The following is a description of a gene set: from publication Sawant DV, Sehra S, Nguyen ET, Jadhav R, Englert K, Shinnakasu R, Hangoc G, Broxmeyer HE, Nakayama T, Perumal NB, Kaplan MH, Dent AL (PMID 23053511) Genes down-regulated in T reg: BCL6 knockout versus wildtype. studied in species Homo sapiens gene expression data from wild-type and Bcl6-/- regulatory T cells in order to find genes regulated by Bcl6 in Treg cells Human Gene Set: GSE40493_BCL6_KO_VS_WT_TREG_DN, and this is the list of marker genes: GRK3, BDKRB1, ITGB4, ICOSLG, CD96, WNT1, TNP2 (transition protein 2), ACHE, SYT8, IZUMO1R, PAK5, PCSK9, NCCRP1, GRIK1, AKNAD1, C11orf87, C2CD4B, KRTAP3-1, CXCL13, SCN2B, ANO4, LRATD1, LHX2, RFX4, GPR151, GPR37L1, MIR365B, PREX2, GDPD4, SHBG, CBLC, PLB1, OSR2, KCNH2, SPACA3, HKDC1, GDPD2, CYP27B1, NPPA, USP18 (ubiquitin specific peptidase 18), MOXD2P, DGKK, SPRR2B, LELP1 (late cornified envelope like proline rich 1), GABRQ (gamma-aminobutyric acid type A receptor subunit theta), SYT13, FMO4, SLC45A2, MIR188, SFXN2, NT5C1A, CDHR4, MIR708, GPR27, DSG2, LPAR2, MIR185, CREB3L3, PNPLA3 (patatin like phospholipase domain containing 3), MYLK3, ACER2, TUBB4A, FOXA1, SAMD5, XIRP1, SIGLEC15, CCDC184 (coiled-coil domain containing 184), DYNLT2B, HDHD5, NEK11, MSMB, TSHB, ALG8, TTC16, ATP13A5, DSCAML1 (DS cell adhesion molecule like 1), ADARB2, VWA3B (von Willebrand factor A domain containing 3B), CTSLP3, RSPH6A, SEZ6L, PRSS36, OR1D2, COX4I1, ZP3, TEKT3, MIR210, GALNT14, SELP, KPNA7, IGFL3 (NCBI Gene Id 388555), NOG, CES5A, MYH8, MIR328, XCL1, CALHM3, TNFRSF19, CHRNE, CLDND2, SMIM31, ABCG8, MIR485, PCDH12, ATP4A, LYPD5, ZIC4, CAND2, SLC29A2, ITGB6, COL6A6, SNTG1, ARC, ACSS3, WFDC9, FMN2, ALOXE3